The following is a description of a gene set: Human Gene Set: MIR4292 species: Homo sapiens from publication Chen Y, Wang X (PMID 31504780) Genes predicted to be targets of miRBase v22 microRNA hsa-miR-4292 in miRDB v6.0 with MirTarget v4 prediction scores > 80 (high confidence targets)., and this is the list of marker genes: ZNF322, CBX7, SPEN, IGLON5, MIEF2, RNF44 (ring finger protein 44), HIP1, DAGLA, WFIKKN2, SLC45A4, CIMAP3, FBXO41, RHOBTB1 (Rho related BTB domain containing 1), APBA1, MKRN1, TTC39C, PRH2, NECTIN1, SLC26A9, ZNF395, ZNF362, ORAI3, ELFN2, CDC42BPG, DYRK2, ARHGAP36, CASTOR2, USH2A, TRIM10, CMKLR1, ZNF862, RNF220, BCL2L2-PABPN1, ST8SIA2, PHF24, MGA, TBC1D16, HSPB7, CAPN15, SAMD10, IQCG, ARHGAP18, UBASH3B, RCE1, PPP3CB, KMT5C, EPB41L4A, CRTC1, AAK1, CPLX2, PHF21A (PHD finger protein 21A), AP1M1, NINJ1, PTPN9, MYOCD, TANC2, METTL1, TMEM164, NCAM1, NBL1, CARMIL3, RNF19B, SLIT2, IRF1, NALF2, MOSPD3 (motile sperm domain containing 3), NOS1, CLEC14A, PLEC, TBX15, XYLT1, PLK3, TMEM35A, CPSF7, OSBPL3 (oxysterol binding protein like 3), UNC5A, FAM234A, NCDN, TACC2 (NCBI Gene Id 10579), EPOP, FBXL19, MTCL2, STAT2, ERGIC1, MAP3K14, POU3F2 (POU class 3 homeobox 2), P2RY2, TPBGL (trophoblast glycoprotein like), NFYC, UBE2Z, MLLT1, HDAC7, TLCD2, SPRY3, GATAD2B, SAMD14, PI4KB, FIBCD1, VASH1, LMOD1, ZBTB40, CCDC102A, FOSL2, PDCD4, CDR2L, RALGPS1, RLF, WAPL, STXBP5, TNPO1, IQSEC3, C4orf19, C19orf73, DDX6, TMEM8B, TSPAN18, SDC3, IL1RAP, GARS1 (glycyl-tRNA synthetase 1), INPP5F, GPSM1, MLLT6, PPM1F, BBS1, MAPRE3, DESI1, C1orf167, CALN1, SH3BGRL2 (NCBI Gene Id 83699), WNT4, CDCA3, TBC1D2, WDR47, MDGA1, LDB1, GYPC, TMEM229B, STYK1, SHISAL1, KY (NCBI Gene Id 339855), ATXN7L3, ZBTB34, LHX9, ZNF335, RNPEPL1, PIK3CA, SH3PXD2B, CLIP3, DCAF7, RIMS4, ITGB1, ZFAND3, GALNT16, MLEC, RGMA, CPNE5 (copine 5), GARRE1, PDGFRB, PABPN1, ADAR, CDC25A